Given this list of marker genes Plaat3, Foxe3, Med1, Tgfbr1, Cited2, Nf2, Birc7, Crybg3, Pds5b, Crybb2, Lim2, Adamts9, Frs2, Crybb1, Sox1, Kdm5b, Ctnnb1, Spry1, Ndp, Tmod1, Pds5a, Smarca4, Hipk2, Smad3, Cdkn1b, Vim, Hipk1 (homeodomain interacting protein kinase 1), Sox11, Slc7a11, Crygc, Cryge, Bfsp1, Bcar3, Crygn, Spred3, Cryaa, Bfsp2, Gja1, Cryba1, Crygb, Gja8 (NCBI Gene Id 16928), Spry2, Tgfb1, Ctns, Pax6, Nhs, Sox2, Crygd, Gata3, Tbc1d20, Zeb2, Cryga, Mip, Dlg1, Plaat1, Spred2, Shroom2, Skil, Meis1 (NCBI Gene Id 353058), Atf4, Epha2, Pygo2, Lctl, Six5, Ski, Crygs, Cryab, Fzr1, Nectin3, Fgfr3, Prox1, Nectin1, Six3, Slitrk6, Fat1, Crybb3, Ntrk3, Unc45b, Gje1, Spred1, Hsf4, Cryba2, Crygf, Fgf2, Bmp4, Tgfbr2, Tbc1d32, Maf, Cdon, Cdkn1c, Tfap2a, Pitx3 (NCBI Gene Id 226171), Abi2, Pou2f1, Tdrd7, Fgfr2, Cryba4, here is a description of the gene set: The process whose specific outcome is the progression of the lens over time, from its formation to the mature structure. The lens is a transparent structure in the eye through which light is focused onto the retina. An example of this process is found in Mus musculus. species: Mus musculus Mouse Gene Set: GOBP_LENS_DEVELOPMENT_IN_CAMERA_TYPE_EYE